The following is a description of a gene set: from publication Gautam P, Hamashima K, Chen Y, Zeng Y, Makovoz B, Parikh BH, Lee HY, Lau KA, Su X, Wong RCB, Chan WK, Li H, Blenkinsop TA, Loh YH (PMID 34584087) Occular cell types curated from Gautam and Hamashima et al. Multi-species single-cell transcriptomic analysis of ocular compartment regulons studied in species Homo sapiens Human Gene Set: GAUTAM_EYE_IRIS_CILIARY_BODY_PUTATIVE_STEM_CELLS, and this is the list of marker genes: UQCRB, MANBAL, TM9SF2, PLPP5, PABPC4, MAP2K3, PTPA, SLC25A39, ABI2, RAB6B, ALDH4A1, DGCR6L, PHF10 (PHD finger protein 10), EGOT, PEMT, ECRG4, CIB1 (NCBI Gene Id 10519), PLOD2, SELENOS, DNAJB11, NEDD8, GRAMD1B, ATP6V1H, TMEM147, CPNE5 (copine 5), MAN2A2, SIPA1L1, SARAF, ARL4A, ABHD14A, IFT80, LHX9, TEX2 (testis expressed 2), PITPNM2, MPHOSPH8, BCAP31 (B cell receptor associated protein 31), ATP5IF1, MEGF9, SLC20A2, CDH6, MALAT1, DIO3, NBEA, TM4SF18, TLCD4, COX16, CRYZ, CXADR, SMCO4, APCDD1L, P2RY6, PDCD7, TGFB3, EBAG9, MGST2, ACAP2, BTF3L4, CTNNAL1, CDR2, GUCY1A2, TIMM10, RHEB, CD151, PEBP1, TPP1, PLXNA2, LRRFIP1, DYNLRB1, MGST3, SLC5A6, LGALS3BP, RPA1, KIF1A, ANAPC11 (NCBI Gene Id 51529), DUSP6, WWTR1, HMOX1, NDUFAB1, FCGRT, DLGAP1-AS2, REEP5, UAP1, C1orf21, PPP1R21, ERP29, BSPRY, HAGH, MRPL33, ELOB, DYNC1I1, RBM47, PBXIP1, OTX1, RSBN1L, AHSA2P, RIN2, LHFPL6, CHPT1 (choline phosphotransferase 1), PTPRD, TPBG, SMARCA2, ZMYND8, STON1, ATP5F1E, SYVN1, HDLBP, TMEM184B, LARP1 (La ribonucleoprotein 1, translational regulator), RNF130, LINC01085, SEL1L, C5orf24 (chromosome 5 open reading frame 24), MED19, NCKAP1 (NCK associated protein 1), NAA38, ZBED5-AS1, FBXO44, ROMO1, PBX3, NDUFS6, PTMS, NQO1, SERF2, UBB, NUDT14 (nudix hydrolase 14), NPC1, ATP6V0E2, PDLIM5, LSR, RRAGD, NCS1, MRPL20, ACYP2, VSTM2L, SNCAIP, MCAM, NFIA, CHI3L1, PNPLA6, DYNLL1, ANTXR1, PINK1, OST4, AMFR, SLC25A6, PPP1R7, SPAG7, ACTN1, SLCO4A1, ZMPSTE24, SEMA6D, AEBP1, INPPL1, PKP4, TMEM98, MARS1, TMEM164, DGKG, ATN1, STX3, EIF2B5, TRIO, RHOC, ATP6V1F, SLC46A3, NUDT4, MYH9, CNIH1, QSOX1, LGMN, MBNL2, CXXC4, JTB, ZNF91, SYNGR1, AMER2, CD320, C1orf122, SNRNP70 (NCBI Gene Id 6625), CDC42EP3, BLCAP, ETFB, KCTD6, HERPUD1, TNFRSF19, RAMP1, UBR4, TMEM50B, SEMA3A, DCBLD2, SLC38A2, PLCB4, PDIA6, PDE4DIP, TSPAN3, DTNA, FAR1, CUTA, NFIB, LAPTM4B, SYMPK, SERPINF2, ATP5PD, PM20D2, ACSS1, ANGPTL4, DENND2B, FZD4 (NCBI Gene Id 8322), WNK2, IRF2BPL, ABHD6, PLXNB1, SNRPG, RAB27A, BANF1, HYOU1, RIDA, DNAJB9, PRDX6, SNORA50C, PPIA, TMEM47, LRRC42, NDUFS7, SPCS3, APEX1, EPCAM, USP2, RAX, SERINC1, TMEM245, RASSF8-AS1, TIMM17A, SYNGR2, SGMS2, B3GAT3, CCDC107, VCL, CADM1, PRDX3, GAPDH, SRSF1, OSBPL6, S100B, STT3B, TRIM9, NUCB1, CCNL2, SLIRP, CORO1C, FAM120A, NENF, NDFIP1, TLN2, TMEM14B, TMEM248, NDUFB5, DVL3, MICOS13, TBC1D1, SYNPO, MYL6, ADAMTS9-AS1, ITPR1, RNF207, ITPRID2, PDXDC1 (pyridoxal dependent decarboxylase domain containing 1), PPP2R5C, SH3KBP1, ABR, ARPC5L, HADHB, TRAPPC1, PLXNB2, CAMSAP2, PMVK, CNTNAP3B, ATP1A3, RHBDD2, CPXM2, LGALS9, QTRT1, CPEB4, PIK3R3, PRMT9, ACBD5, NAV2-AS4 (NAV2 antisense RNA 4), ALKBH7, LRRN2, NDUFA8, HSPA9, FOCAD